Given this list of marker genes GRIN2D, GRIN1, GRIN2A, GRIN2B, GRIN2C, here is a description of the gene set: Pathway Definition from KEGG: Glutamate -> NMDAR -> Ca2+ species: Homo sapiens Transport of calcium. Pathway ID: N00970. Pathway type: Reference. Pathway class: nt06460 Alzheimer disease. Human Gene Set: KEGG_MEDICUS_REFERENCE_TRANSPORT_OF_CALCIUM